The following is a description of a gene set: from publication Mikkelsen TS, Hanna J, Zhang X, Ku M, Wernig M, Schorderet P, Bernstein BE, Jaenisch R, Lander ES, Meissner A (PMID 18509334) Human Gene Set: MIKKELSEN_DEDIFFERENTIATED_STATE_UP species: Mus musculus Somatic cells can be reprogrammed to a pluripotent state through the ectopic expression of defined transcription factors. Understanding the mechanism and kinetics of this transformation may shed light on the nature of developmental potency and suggest strategies with improved efficiency or safety. Here we report an integrative genomic analysis of reprogramming of mouse fibroblasts and B lymphocytes. Lineage-committed cells show a complex response to the ectopic expression involving induction of genes downstream of individual reprogramming factors. Fully reprogrammed cells show gene expression and epigenetic states that are highly similar to embryonic stem cells. In contrast, stable partially reprogrammed cell lines show reactivation of a distinctive subset of stem-cell-related genes, incomplete repression of lineage-specifying transcription factors, and DNA hypermethylation at pluripotency-related loci. These observations suggest that some cells may become trapped in partially reprogrammed states owing to incomplete repression of transcription factors, and that DNA de-methylation is an inefficient step in the transition to pluripotency. We demonstrate that RNA inhibition of transcription factors can facilitate reprogramming, and that treatment with DNA methyltransferase inhibitors can improve the overall efficiency of the reprogramming process. Genes up-regulated in partially reprogrammed and pluripotent cell populations (induced, iPS; and embryonic stem cells, ES) compared to parental lineage-commited cell lines., and this is the list of marker genes: DSG2 (desmoglein 2), FGF4 (NCBI Gene Id 2249), FBXO15, ZIC3, PHC1, ETV5, COBL, JARID2